The following is a description of a gene set: species: Mus musculus Mouse Gene Set: GOBP_MRNA_PSEUDOURIDINE_SYNTHESIS The intramolecular conversion of uridine to pseudouridine in an mRNA molecule., and this is the list of marker genes: Pus1, Trub2, Dkc1, Pus7l, Rpusd4, Pus7, Rpusd3, Pus3, Trub1, Rpusd2